Given this list of marker genes PCBP4, ZNF385A, TP53, CDKN1A, here is a description of the gene set: part of: p53-Dependent G1 DNA Damage Response Reactome Pathway: Transcriptional activation of p53 responsive genes species: Homo sapiens p53 causes G1 arrest by inducing the expression of a cell cycle inhibitor, p21. P21 binds and inactivates Cyclin-Cdk complexes that mediate G1/S progression, resulting in lack of phosphorylation of Rb, E2F sequestration and cell cycle arrest at the G1/S transition. Mice with a homozygous deletion of p21 gene are deficient in their ability to undergo a G1/S arrest in response to DNA damage.